The following is a description of a gene set: Genes predicted to be targets of miRBase v22 microRNA hsa-miR-6881-3p in miRDB v6.0 with MirTarget v4 prediction scores > 80 (high confidence targets). from publication Chen Y, Wang X (PMID 31504780) species: Homo sapiens Human Gene Set: MIR6881_3P, and this is the list of marker genes: MBNL1 (muscleblind like splicing regulator 1), ZMAT4, SLC8A3, ARK2C, CERS6, CNOT6, ACKR4, ATRNL1, SDC3, EEIG2, RAB3IP, ACOT13, SRP19, PLXNA4 (plexin A4), EEF1A2, CUL2, DELE1, MRE11, CTBP2, AGO1, PRRX1, STK38L, HMGXB4, AFF1, HNRNPU, HPGD, NAA40, THSD7A, ARHGAP26, ATXN1, FEM1B, KBTBD11, TYW1B, ATP8B2, SH3TC2, ATP5IF1, ZNF18, PMEPA1 (NCBI Gene Id 56937), EPHB2, NALF1, ADGRL3, SGMS2, GRIA3, GABARAP, IGF2BP2, VPS37A, CNNM4, PTGFRN, IKZF5, CCDC186, ANTXR2, NABP1, FN3KRP, FZD7, MAPK10, SPOCK1, INSIG2 (insulin induced gene 2), PPHLN1, CLEC7A, THUMPD1, SERINC5, LIN54, SSTR2, ZDHHC21, AFG2A, ZNF420, PABIR2, CHST2, DAAM1, GAGE1, ZBTB34, RBFOX2, DNAJC21, FOXJ2, PRMT5 (NCBI Gene Id 415048), EBF1, PPP1R11, NUP50, RAB3C, MYBBP1A, ZBTB20, ZNF470, UGGT1, SETD6, PAXBP1, SPIC, SPTLC1, SLC30A8, MICOS10, ZNF559, SCIN, TANC1, ZNF704, RBM7, SPAST, KIF5B, XPO4, BRCC3 (BRCA1/BRCA2-containing complex subunit 3), CELSR2, SYPL2, LACC1, GRIP1, SLC25A33, NOX4, STON2, LYST, MEF2C, HSD17B12, ELAVL4, PCDH15, MIB1, MED23 (NCBI Gene Id 9439), PABPN1, SETX, TMEM98, SPN, ROR1, ADAMTS15, CREBBP, CREG1, MTTP, DIO2, C10orf55, FAM120AOS, RBM41, RAET1E, CDK14, PBX1, ARHGAP9, FBN2, CHST11, WRN, FN1, PPP1R8, NR1D2, SLC30A1, ADM, RNPC3, EFNB1, CDK5RAP3, AFDN, TYW1, MACO1, RIMS2, BRWD1, MMP16, CLMP, MYCBP2, WSCD2, MEGF11 (NCBI Gene Id 84465), ARFGEF3, PPFIA2, KCNJ2, TM4SF4, LPGAT1, SUMF1, SCO1, MRPL33, TMPO, ADAM22, CYRIA, CEBPD, EXOC8, RAP2B, MCCC1, SH3D19, SCN1A, CD93, SPSB4, TRIM10, ILRUN, CAMK1D, ACTN1, GRPEL1, FGF18, RBMS3, UBN2, TRMT1L, CD226, EDARADD (EDAR associated via death domain), LMOD2